The following is a description of a gene set: Human Gene Set: HP_LIMB_UNDERGROWTH Limb undergrowth studied in species Homo sapiens Limb shortening because of underdevelopment of one or more bones of the extremities., and this is the list of marker genes: BRIP1, CCNQ, IFT140, WNT5A, FREM2, ERCC4, BRCA1, EVC, ARCN1, DVL3, TCTN3, PRKAR1A, CILK1, SF3B4, EVC2, COL11A2, RPL26, EIF4A3, FANCA, ALG9, ACAN, FN1, DYM, HRAS, AFF3, CLTCL1, GDF5, IDH2, TBCK, POLE, RPS19, RAC1, PSMD12, NXN, TBX15, GLB1, COL9A2, DYNC2I1, SLC26A2, BPNT2, MAFB, GNAS, RAD51C, GNPNAT1, IFT80, KIAA0753, SCARF2, EXT1, CSGALNACT1, IFT172 (intraflagellar transport 172), COL2A1, CSPP1, ADAMTS2, GRIP1, PUF60, UBE2T, EXOC6B (exocyst complex component 6B), EFNB1, EBP, RNU4ATAC, ARL6IP6, RAD21, PDE4D, GSC, FZD2, CRTAP (NCBI Gene Id 253263), AFF4, ALPL, NGLY1, COL11A1, TBX5, PPIB, TAF6, RTL1, LAMA5, HDAC6, FANCD2, MAD2L2, ADNP, WNT7A, MYSM1, ANTXR2, RBM8A (RNA binding motif protein 8A), RFWD3, NEK1, FGFR1, GHR, ACTB, ATR, B3GLCT, B3GAT3, CHN1, PKDCC, IDH1, PHGDH, CEP120, KIF15, RMRP, ZSWIM6, PTH1R, FANCE, XRCC4 (NCBI Gene Id 7518), ROR2, FGF10, GLI3, WDR35, SIK3 (NCBI Gene Id 80236), GPC6, SHOX, EXTL3, TRPV4, BPTF, FRAS1, DYNC2I2, NPR2, PRKACA, GPX4, MTOR, SLC39A8, TAPT1, FANCI, COMP, CCDC8, GAD1, POC1A, FANCL, HHAT, CEP57, FANCB, BRD4, APC, COL1A1, AGPS, DONSON, SMC3, CHST3, DYNC2LI1, DHODH, HYLS1, EXT2, PCYT1A, BRCA2, DVL1, FUT8, FANCF, WDR19, MBTPS2, CFAP410, KIAA0586 (KIAA0586), IFT52, PCNT, FGFR3, ERI1, FAM20C, DHCR7, LONP1, DHCR24, GNPAT, ASXL1, IFT43, SMC1A, MMP9, FLNA, PAPSS2, INPPL1, BMPR1B, DPYD, VPS35L, CREB3L1, COL10A1, ACP5, SERPINH1, SLC35D1, FANCG, HSPG2, CLPB, LTBP3, TRIP11, DYNC2H1, NBAS, B2M, FANCC, DLK1, OBSL1, MMP13, COL1A2, DDRGK1, CHD7, ALG12, SMO, PLCB3 (NCBI Gene Id 5331), PDHA1, MATN3, GLI1, KMT2A, B9D1, PEX7, NOG (NCBI Gene Id 9241), GLUL, LIFR, DPM1, MAB21L2, TONSL, SALL4, CCN2, CTSK, ZNF699, PIGT, SLC35C1, IHH, NIPBL, TBX3, FLNB, ESCO2, XRCC2, JAG1, FANCM, RBM10, SLX4, COG1, NIN, GNA11, HDAC8, RIPK4, RAD51, CUL7, FGFR2, MEG3, PRKACB, PAM16, DDR2, CD96, CDKN1C, PIGY, CHUK, LBR, IFT81, RECQL4, KYNU, KIF7, COL9A3, PALB2 (partner and localizer of BRCA2), COL9A1, IFT122, PRKG2, TTC21B, LRP4